The following is a description of a gene set: studied in species Homo sapiens The region of a polarized cell that forms a tip or is distal to a base. For example, in a polarized epithelial cell, the apical region has an exposed surface and lies opposite to the basal lamina that separates the epithelium from other tissue. Human Gene Set: GOCC_APICAL_PART_OF_CELL, and this is the list of marker genes: DYNC2H1, ACVR1, NHERF2, SLC7A5, ATP4A, SLC5A2, PROM2, CETN2, CYP4F12, SLC4A5, S100G, SLC3A2, SLC5A1, SLC9A2, MSN, PRKAA1, PLPP1, SLC11A2, SLC7A11, SLC46A1, HIP1R, ENPP3, CIB1, LDLR, MGAM, PDPN, ATP6V0D1, SLC5A10, MTCL1, ATP4B, GNAT3, SLC22A11, SLC7A1, NEDD1, PLD1, THY1, TMEM235, SHROOM3, SLC44A4, CNTFR, CEACAM6, SCNN1D, SVBP, NHS, PARD6G, SLC6A20, CRB3, MLC1, IQGAP1, SLC39A8, SLC12A2, F2RL2, ITPK1, SLC5A12, SHROOM4, UPK3A, CRB2, CASR, GNAS, DSG2, DSG1, RDX, BYSL, SLC22A18, CUBN, CFAP126, STK39, MAL2, SLC38A1, INSC, SLC6A19, ADAM17, ACE2, PDE4D, SLC20A2, ABCC1, CLCN5, USH1C, ITGB3, PAPPA2, FXYD1 (NCBI Gene Id 5348), KCNA5, CRB1, SPECC1, FOLR1, SLC9A8 (NCBI Gene Id 23315), HOMER1, DPEP1, SLC17A1 (NCBI Gene Id 6568), SLC6A18 (solute carrier family 6 member 18), NRG1, SLC2A2, WDPCP, SLC16A2 (NCBI Gene Id 6567), SLC17A4, TMEM174, ABCB11, DDR2 (NCBI Gene Id 4921), P2RY1, PTCH1, ADRB2, DRAM2, EZR, RAPGEF6 (NCBI Gene Id 51735), KCNB1, LRRC15, ENPEP, KCNE2, ATP6V1B2, PATJ, CTSL, GM2A, SLC39A4, ATP2B2, SI, NOD1, SLC9A4, CLDN1, CA12, ERBB3, ASIC5 (acid sensing ion channel subunit family member 5), MPDZ, SEPTIN7, ATP6V1A, ITPR3, GPIHBP1, ATP1A1, SCNN1A, PTPRH, SHANK2, CYP4A11, SLC15A1, ABCG8 (ATP binding cassette subfamily G member 8), MAL, MREG, CTNNB1, PTEN, BMPR2, RAB27A, SLC52A3, PDZK1, DUOXA2, RIPOR2, SLC4A11, SRR, IL10RA, MTDH, PDZK1IP1, SLC10A2, KCNK2, PLAT, RAB17, NPC1L1, SLC2A7, GNAT1, ABCB5, SLC26A2, TRPV4, AQP1, SLC47A1, SLC28A1, DCHS1, GPR143, ADGRF5, PALS1, SIPA1L3, OCEL1, OSMR, CLDND1, SLC13A1, SLC12A3, TRPA1, PLET1, LHFPL5, AP2A1, C1QTNF5, AQP10, TNIK, SLC16A3, DPP4, AKR1A1, TUBG1, CYBA, TRPM6, CEACAM1, SLC6A8, RAPGEF2, IFIT5 (interferon induced protein with tetratricopeptide repeats 5), OTOA, MYO5B (NCBI Gene Id 4645), SLC16A1, SLC22A3, ABCB1, ZMYND10, SLC47A2, HSP90AA1, SLC2A9 (NCBI Gene Id 56606), AKAP7 (NCBI Gene Id 9465), MUC1, UPK2, CD44, SLC26A6, SLC22A13 (NCBI Gene Id 9390), ABCC2, CRIPTO, TCHP, USH2A, PODXL, KIAA1614, SLC6A6, SCNN1B, LCT, CA4, SLC26A11, CHL1, SLC23A1, FABP2, SLC2A5 (NCBI Gene Id 6518), SLCO2B1, UPK1A, SLC1A1, DSTYK, CDH2, SLC39A3, SLC22A7, CEACAM20, KCNE1, AHCYL1, ACTG1, EDAR, CDHR5, GP2, HFE, CNKSR3, SLC26A3, KL, BST2, GABRP, NF2, SPEF1, IL6R, FAT1, VANGL2, TLR9, SLC14A2, NHERF1 (NHERF family PDZ scaffold protein 1), KCNC2, HPN, ATP6V1G1, SLC15A2, PFKM, RAB27B, NOTCH1, LMO7, MYO6, HAX1, KNCN, ACP3 (NCBI Gene Id 55), SLC5A8, SHROOM1, GJB6, PTH1R, CTSB, TMEM114, ADCY10, SLC23A2, SLC29A4, HYAL2, OCLN, P2RX2, SLC30A5, SLC5A11, MUC17, CD300LG, ECRG4, TMEM30A, AJM1, IGSF5, MIR181A2 (microRNA 181a-2), PTPRO, PDZK1P1, ABCC4, PALM2AKAP2, SLC22A1, SLC25A27, SLC9B2, SLC7A9, CBLIF, JAG1, SLC17A2, SLC22A5, CDHR2, MYO7B, AJAP1 (NCBI Gene Id 55966), SLC4A10, SLCO1A2, CYP4F2 (cytochrome P450 family 4 subfamily F member 2), SLC4A7, LRP2, STX3, SCNN1G, AGER, PCM1, SHROOM2, SLC4A9, ADCY8, ABCG2, PARD3, FLOT2, VCAM1, EMP2, SLC29A1, EPS15, PTPRQ, SLC34A2, TJP1 (NCBI Gene Id 7082), LGMN, CLIC5, MUC20, SLC2A1, CFTR, SLC34A3, NHERF4, FZD3, PLLP, ITGA8, DNAAF11, SLC2A13, SLC36A1, CPO, CA14, SLC22A8, TF, CSPG4, EDA, SLC17A3, AQP8, SLC39A10, AMN, ANXA1, DUOX2, RAB18, MPP3, ATP6V0A4, MFSD4B, UPK1B, ABCB4, NIN, ABCC5, SLC26A7, ADGRG2, AQP5, SLC22A2, KCNE4, SLC22A4, C2CD2L, ERBB2, SNX10, REN, OTOG, CEACAM7, NAALADL1, SLC6A9, ATP1B2, ANXA13, SLC9A3, SLC4A2, SLC26A4, CYBRD1, SLC3A1, SLC7A13, SPTBN5, PARD3B, FRMPD2, SLC39A6, MIP, EPCAM, ATP8B1, SLC4A8, PKHD1, ATP6V1E1, ANO1, ATP12A, DVL2, KCNMA1, SORBS2, SLC26A9, ATP6V1C1, FRMD6, SLC39A14, SLC13A2, DLG1, ATP6V0D2, FRMD1, MARVELD2, STXBP2, SLC7A8, ATP1B3, RHCG, FZD6, MYL12B, SLC38A3, AQP2, CDC42, SLC24A4, ARHGEF18 (Rho/Rac guanine nucleotide exchange factor 18), SLC5A6, STXBP3, EPB41L4B, PROM1, SLC29A2, TRPV5, DYNC2LI1, UMOD, CLDN4, SLC22A12, ANK2, FAP, ASPM, TEK, HVCN1, NUMB, CA2, KCNK1, PARD6A, ATP6V1B1, NEDD4L, SLC12A1, SAPCD2, VASH1, HOMER2, PRKG2, PDGFRB, PRKCZ, MUC13, SLC5A3, IGFBP2, MYO1A, STK26, SLC6A14, CD9, ABCC11, ACY3, SLC19A1, FN1, KCNQ1, SLCO3A1, CEACAM5, MFRP, SLC17A5, ATP1B1, STC1, SLC16A8, SLC31A1, ABCG5, PRKCI, SLC43A1, SLC9A1, MYO7A, DLL1, SPTBN2, CAV1, CLCA4, PLB1, FLOT1, PARD6B, CD34, DUOX1, GJA1, SLC34A1, CLIC4, CD36, CTSK, C5AR1, C5AR2, TCIRG1